Given this list of marker genes KDM5A, RIOX1, KDM5B, KDM5C, KDM5D, here is a description of the gene set: Catalysis of the removal of a methyl group from a tri, a di or a monomethyl-lysine residue at position 4 of the histone H3 protein. This is a dioxygenase reaction that is dependent on Fe(II) and 2-oxoglutarate. studied in species Homo sapiens Human Gene Set: GOMF_HISTONE_H3K4ME_H3K4ME2_H3K4ME3_DEMETHYLASE_ACTIVITY